The following is a description of a gene set: Human Gene Set: ZNF134_TARGET_GENES studied in species Homo sapiens from publication Yevshin I, Sharipov R, Kolmykov S, Kondrakhin Y, Kolpakov F (PMID 30445619) Genes containing one or more binding sites for (ZNF134) in their promoter regions (TSS -1000,+100 bp) as identified by GTRD version 20.06 ChIP-seq harmonization., and this is the list of marker genes: ELSPBP1, NRG4, HM13-AS1, THAP11, SCUBE2, SPOP, PADI2, LINC01409, RPS19, HLA-DMA, TNFSF13, HHAT, MCF2L, TTC24, PIGN, DOCK5, SCRN3, RBBP5, CUTA, MIR762HG, BLM, FSIP2LP, PRRG2, SQOR, TMPRSS2, FUNDC1, MT-RNR1, SCGN, GLDN, LINC01972, CCDC163, LINC01690, COL4A2, TMEM9, PHB1, C1RL-AS1, DNAJA2, LINC02041, MIR3621, KAZALD1, DLD, CCKBR, EFR3B, CLCN7, ATF6B, LINC01803, PXN, DUSP14, FHIP1B, IQSEC2, DROSHA, ZC3H12C, C10orf95-AS1, PSMA5, NUBPL-DT, MXD3, ERMN, DZIP3, STRA6, CRISPLD1, CD99L2, MAN1C1, STC2, POLR1B, OAS2, ARV1, LY6G5C, SF1 (splicing factor 1), ENSG00000233461, MAP4K1 (mitogen-activated protein kinase kinase kinase kinase 1), EPRS1, TUBG2, ZNF761, WEE2-AS1, LRRC10B, EEF1AKMT3, MIR1-1HG, CLDN6, MIR182, COPS7A, EVI5, C4orf50, LINC00649, AGAP3, DRC7, PNP, PSEN1, FOXN1, PPCDC, SELENOH, BCAT2, DPP8, COMMD3, ERCC1, RAI14, FOXP1, FOSB, PCGF6, RGL2 (ral guanine nucleotide dissociation stimulator like 2), SYNJ2BP-COX16, C5AR1, ALDH7A1, CDH13-AS2, UTP6, YBX3, LINC00111, NABP1, SLC25A15, MPG, GCSIR, PTPRF, YARS1, ELL, HOXC4, ATP6V1G1P5, WDR45, BORCS7, SNAP91, ISG20, DCTN1, ZNF565, NFE2, TOGARAM1, EGLN2, HACD2, TMEM101, RBMS3, CNN3, LRP10, VARS1, MIR933, KIF20B, R3HDM2-DT, FLAD1, PITPNM1, PRPF8, PDK4-AS1, ZNF616, DCUN1D3, CACNA1A, EML3, ZNF292, DST, TSNAX, GOT2, SOAT1, SLC11A2, SEC61G, FKBP15, SREBF1, B4GALNT4, IGDCC4, ZNF708, ITGA11, SLC22A11, TRAK2, CHMP6, NTN3 (netrin 3), FBXO27, SH3KBP1 (NCBI Gene Id 94010), ZNF460, PGGT1B, PDCD11, ZGRF1, EFL1P1, RNU4-60P, MRPL21, NSL1, CLVS2, CREM, EFEMP2, ZNF829, ALOXE3, SYNRG, BMPR1B, SYTL1 (synaptotagmin like 1), TEX10, ZSCAN31, CFLAR, SKAP2 (NCBI Gene Id 8935), OBSL1, GNAI3, SULT1A1, ZNF460-AS1, NIBAN1, NDUFA11, DCLRE1B, CCSAP, SEC24B, NLGN1, NCSTN, GCLM, BAIAP3, C5orf22, RNU6ATAC34P, ILF2, RPS6, ADAMTS13, SCAF4, PRR14, NFYA, FLII, RPL5, KRAS, WDR55, EXOC2, PIEZO2, ZNF160, LSMEM1, LINC02614, TENT5C, OARD1, TLCD3B, EME1, PRPH, LINC01063, LINC01132, LNCRNA-IUR, MIR4661, CIR1, HEATR1, ZEB1, EPHX1, RUSC1, DDOST, PPIEL, DYRK1A, TCHP, SFN (NCBI Gene Id 2810), LINC01152, SNUPN, GABPB2, ZNF429 (zinc finger protein 429), ENSG00000269151, RNF125, OSBPL7, MPND, ANKS3, BAZ2B, CEACAM1, UBE2V1 (NCBI Gene Id 7335), BMS1P4, TRIB1, OSBPL3, HMG20A, SYNJ2BP, SEH1L (NCBI Gene Id 81929), TLE6, JAKMIP2, SPCS2P2 (signal peptidase complex subunit 2 pseudogene 2), KIF3C, AKAP8, SEPTIN9-DT, DNA2, ZNF711, ANAPC2, PEAR1, RTEL1, SPECC1, SPTB, ATP2C1, MAP3K12, ENSG00000267698, ADHFE1 (NCBI Gene Id 137872), CHKB, SLC46A3, BFSP1, LINC02366 (long intergenic non-protein coding RNA 2366), GGA3, TCTN1, ACVR1C, CLPB, SREK1 (splicing regulatory glutamic acid and lysine rich protein 1), IL6, PIK3R2, CNEP1R1, MFAP3, PAMR1, ATXN1, IPO9-AS1, ANAPC5, ORC4, ATP5MC2, USP4, SF3A3, SZRD1, SDSL, DYRK1B, ESCO1 (establishment of sister chromatid cohesion N-acetyltransferase 1), PHETA1, COL9A3, WDR7, RASD2, CSNK1D, GPR157, NOLC1, TLL2, ZNF892, TBC1D14 (NCBI Gene Id 57533), TTF2, MIR4664, CD101-AS1, MTMR4, STAP2, NT5DC3, SLC12A6, RPS6KB1, ECHDC3, C9orf43, PDE9A, AGBL5-AS1, PNPLA8, ITGA7, CD72, PUS10, DNASE1, GTF2B, OTULINL, OTX1, PRKCG, CREB3L2, BBS1, SEC14L5, NPHS1, TMC4, ADAMTS1, TTLL6, ARRDC1, DENND4A, SARS2, GOLGB1, MAP2K5, ALDH4A1, ZNF133, THAP5, PDXK, SPNS2, ZNF233, ZNF569, LARP7, RBPJ, RBM26-AS1, LINC01937, STK11, ADGRB3, ZNF362, CGA, ZNF146, CYBA, MBLAC1, TMX4-AS1, KLHL28, TK2, NTAN1, PPP1R3B, ZFP30, GUSBP18, RIF1, PEX13, GPC1, ST7, RPL18, DAB2, ARHGAP27, WDR59, S100A1, TOP3A, SCAMP5, IRF3, DSG1-AS1, H2AZ1-DT, LIN28B, ARMC7, ZCCHC7, TMBIM1, PTCD3, SPSB4, SLC25A30, LINC02453, FBXL19-AS1, TPM3P9, GINS2, PTGES, LARGE2, MRM2, ABCA5, EBP, DPH3, PROSER1, ATG9B, DRAIC (downregulated RNA in cancer, inhibitor of cell invasion and migration), MIR4681, BLOC1S1, RNF115, SMPDL3A, H2AC4, TP53BP1, ACAD9, MAST4-AS1 (MAST4 antisense RNA 1), ATF2, ZNF420, OGT (O-linked N-acetylglucosamine (GlcNAc) transferase), S100A13, MIR4488, TBX18, KDM5A, BTN3A3, GOT1, B3GALNT2, WDR62, SPMIP8, CRHR1, IL23A, SMKR1, SEPTIN9, SMG1P3, SEPTIN11, RABGAP1L, RAD51C, DNAAF9, ZC3H15, APEX1, SYDE1, FOXK2, PUS1-AS1, B3GAT3 (NCBI Gene Id 26229), ZNF436, THAP10, PNRC2, LYRM1, SLC38A6, ZNF668, PNMT, AOPEP, GGNBP2, DPP9, KCTD16, PRRT1, MCCC1, MAST3-AS1, ZNF566, ZNF138, ARRDC3, SLC25A21, JADE2 (NCBI Gene Id 23338), H6PD, STING1, DLGAP5, LIMA1, SRP9, RNASEL, BORCS7-ASMT, CRTC3-AS1, NICN1, ZKSCAN8, VDAC1P8, PHF12, PDZD2, RASSF2, S100PBP, BMS1P4-AGAP5, C2CD3, MIR367, LINC00205, TRMT5, SELL, SBK2, GFAP, TM9SF4, ACTG1P12, HINT3, MICA, CBFA2T2, LARS1, LINC02970 (long intergenic non-protein coding RNA 2970), MIR302D, ANKRD13C, FTCD, STAT6, ITSN1, BRD4, USP44, FAM200A (family with sequence similarity 200 member A), DSN1, AARS1, PRPF18, PDE8A, RNF10, BBS4, LTBP4, TVP23C-CDRT4, TRIM2, KIAA0825, LINC00240, PGAM1P5, CDC14A, B4GALT3, PISD, NR4A1 (NCBI Gene Id 93352), NDUFA5, RNU11, CDK4, MACF1, STK40, BMP8B, RSBN1, PROSER3, SALL1, GAL3ST4, SIRT2, FMR1-AS1, TXNL1, MIR4519, GTPBP3, SGMS1, PACS1, HIP1R, SPTBN4, DNAH2, NR2F1, SEC61G-DT, STUM, SLC30A10, HNRNPR, ZBTB8A, WDR25, ENSG00000215156, GMEB1, TMEM186, CDC42SE1, ALDOA, ATP5MK, FAM114A2, TADA1, ZNF689, KIAA1217, GSAP, EBNA1BP2, PDP2, ZNF570, LNPEP, PEX11A, ABHD12, ZFYVE16, F11R, HOXB-AS3, NDEL1, SEC61A1, YAF2, FZD3, MT-TF, TNS2-AS1, DGKZ, PGAP1, PDE12, SEC22B, TNFAIP2, ZNF330, ARHGAP33, LINC01431, TMEM218, COL5A1, KIF22, SAMD14, DYNC2LI1, GLUD1P3, MCM7, MYLK-AS1, ODAD1, CSNK2B, PPHLN1, CAMSAP2, GABARAPL1, TBCB, PLAUR, TJP2, EEF2K, MAPK8IP3, PAN2, NEK2, NUP43, ANKRD13C-DT, CPNE7, HSPA8, EXOC4, RPL27 (NCBI Gene Id 6155), GLI2, CCDC57, SPHK2, NRP1, MYO3A, GTPBP8, EFHD2-AS1, SNHG22, RDM1, LTBP3, GOPC, TLN1, MIR7850, QRICH1, RPA3, CDR2, NT5M, CCNC, GIP, PDE4D, MSANTD4, BRINP2, PARN, SUGT1P4, C5orf34, IQANK1, LINC00910, TUBA1C, DPH1, TJAP1, NFKBIL1, SBNO1, JPX, MIR548AP, CXADR (NCBI Gene Id 95792), FHAD1, HNRNPD, RPL26, R3HDM2, ZFP36, STAT2, SNORA10, POLE3, ARHGEF37, ROM1, SMARCC2, TUBD1, HSD17B1-AS1, FAM133GP, C5orf47, PPME1, AGPAT5, GBA1, CRYZL1, HMCN1, GUSBP2, MIR22HG, SUPV3L1, ZNF285, EEF1A1, RNU4ATAC16P, MARCHF6, TSPAN12, DNAJB9, F12, BCAR3, TAPBP, VARS2, EGFL7, SGTB, PRPSAP2, PILRA, TM2D1, RUNX2, CCL3-AS1, NHLRC3, KCNAB2, PLXNB3, RNF166, NSUN6, AP1G1 (adaptor related protein complex 1 subunit gamma 1), ZNF655, MTMR9, ARID1A, RMC1, ZMYM5, NUP54, SSBP1, TACC2, PAXBP1, C2CD5, UBXN6, ITGAX, SLC16A13, C9, UACA, VWCE, ZNF85, MCTS2 (MCTS family member 2), FOXP1-DT, ZNF584, DLC1, HOXA9, ACTMAP, PMM2, MRPS31P5, LRRC49, TBCD, NFKBIB, LINC01523, LINC01039, CXXC5, RFFL, ATP6V1G2-DDX39B, ITGA9, PCYT1A, FBXO25, LRP8, HIF1A, PFDN1, SMC1A, ZNF92, VWA7, CPEB4, PCSK7, PAK4, RAB5B, RBMS3-AS3, PSTPIP2, COMMD9, ZNF391, THAP1, TLCD2, PHC2, ARHGAP24, NUB1 (negative regulator of ubiquitin like proteins 1), NID1, PEAK1, BCAP29, ANO8, NRCAM, LINC00957, MCM10, SLF1, FAM199X, MAML1, POLA2, MEGF10, GSK3B-DT, SRCAP, MCFD2, CNN3-DT, CDH23, TATDN3, ENSG00000272008, MAML3, MT1X, MAP3K15, ACIN1, GSR, OSBPL8, TREX1, HNRNPD-DT, TENT5C-DT, RNF19A, UVRAG, LCN15, COX16, PPT2, CDKN1A, KLHL20, RNU7-179P, SF1-DT, LSP1, SNORD21, LYZL6, SRD5A3, MMACHC, RNF145, CRYL1, ATP5MC3, RNF13, FAM8A1, GOT1-DT, SUZ12P1, GTPBP6, ZFHX2, SQSTM1, MFN2, LINC01778, COPA, SPAG1, ARL6IP6, CDK15, PMEL, HOXB-AS1, REPS1, CHEK2, SNORA14B, CTBP2, SDCBPP3, ORAI2, ZFP64, PARP1, KDM4A, ZNF385A, YIPF5, PIK3AP1, PPP6R3, IL12RB1, LINC02458, PYCR1-AS1, FAM186A, ARPC5 (NCBI Gene Id 10092), FBXL19, IKBKB-DT, PYGM, TMCC3 (NCBI Gene Id 57458), NUP153, DOHH, ZNF500, E4F1, RPP21, GFI1, MYL6B, IPO4, METTL1, TBPL1, TAB2, TARBP2, MAST4, KRT8, IER5L-AS1, VPS33B, MDGA1, PATL1, RASA4CP, RIC8A, AGBL5, NUBPL, ARHGAP5, ATP5PD, CHD1, PDE6B, SPRY1, NEMF, CNOT2, GGT1 (NCBI Gene Id 91347), RNF103-CHMP3, MRPL27, OXNAD1, PMVK, PRSS22, SLC9A3R1-AS1, WDR26, TVP23C, DSTN, PDE7A, PKN2, TASOR2, ZNF737, BCAN-AS2, MIR6853, PSMB5, HOGA1 (NCBI Gene Id 112817), ARHGEF7, ALKBH6, TEX14, ZNF714, GNG12-AS1, BEST3, RERE, ENDOG, GTF2H4, LETM2, TMEM184A, NAPEPLD, WDFY1, ROGDI, C1RL, POLR3C, COQ5, CEP89, GLI1, CHKB-CPT1B, TNS2, SLC25A14, NEK2-DT, GLIPR1L1, JUP, GPD1, ATN1, SNORD118, DMAP1, KSR1, RNY1, ZNF287, PHC3, ZDHHC2, CYP2J2, MYO3B-AS1, AMFR, RN7SKP276, CPEB1, CIP2A, SESN3, MGST1, CAMKK1, SALL1P1, RREB1, CSF3R, CHKB-DT, AGPAT1, MTND5P11, LINC01863, TDRD7, FGF1 (NCBI Gene Id 29961), DNAI3, NOSIP, RUSC1-AS1, EPCIP-AS1, AGPAT4, IPO9, PDGFRL, HOMER3, XIAP, SV2C, NPTX1, CARS2, WDR93, PHYHIP, ATP1B3, IDE, CSNK1A1, ENOSF1, DST-AS1, ENSG00000214708, U2AF2, LYPD5, MTCO3P12, ZNF568, ATP6V1G2, CCDC6, C6orf118 (NCBI Gene Id 353266), DUSP18, OSGEP, PPP1R12A-AS2 (NCBI Gene Id 105369864), FKBP14-AS1, CLIC1, H2AC25, HRCT1, CFAP57, ACAN, LGMN (NCBI Gene Id 5641), PRDM4, CCNG1, MPZL1, VPS33B-DT, ERI2, ZNF428, QNG1, ZNF566-AS1, TIAL1, FMR1, RIBC1, LIN37, FHL1P1, WSCD1, HSPB6, ZFP1, HECW2, YAP1, CFDP1, LNCTSI, CEBPB-AS1, BCL2L12, SNRPA, ZNF131, KCNT1, NUFIP2, ST6GALNAC6, EVL, IMP3, MCTS1, NCEH1, METTL9, NPHP4, TTC13, NINJ2, GDI2, HOXB2, DCDC2, LYPLA2, ETV2, RGS9, ZNF672, KDM4B, NMT1, RELCH, AGBL3, TGFBI, CNTNAP2, ASB6, IGHV3-30-2, ZNF229, CCDC88C, CFAP65, MBD5 (methyl-CpG binding domain protein 5), TMEM170A, MCPH1-AS1, RNA5SP433, PDCD2L, ITPR1, POLR3G (RNA polymerase III subunit G), STPG3-AS1, ARHGAP5-AS1, LINC02250, BRD2, TSC22D4, HIGD2B, RNF103, FICD, CIBAR1, BNC2-AS1, RAB11A, VMAC, TVP23B, EFHD2, MARCHF6-DT, PTGES3, DHRS4-AS1, ACHE, UBE2I, IGFBP3, LINC02136, GPANK1, FAM83H, LRP8-DT, PCBP3, SLC1A3-AS1, DHDDS, RAET1K, WFDC2, ACTB, SPEN, SPINT2, NOL4L, SLC2A8, LRRC24, RCOR1, ABR, AKR1A1, ABCG4, GRHL3, EXOSC8, MRPS21, RGL1, HM13, RFC1, PRSS16, CFAP74, KANK3, FAAP24, ENSA, PHLPP2, ALG5, FGGY, CSTB, MC1R, DCTD, MIR760, EPN3, UBE2O, FLOT1, ZNF543, CALM1, POP4, LINC01607, ENSG00000282849, ERCC3, IFT140, CSK, LINC01569, SFR1, ZMYM4, ACP6 (acid phosphatase 6, lysophosphatidic), CDR2-DT, ENSG00000261070, BCRP2, KCTD2, MBTPS2, RNU6-1010P, ANXA2R, SUB1, EP400P1 (EP400 pseudogene 1), CATSPERG, LHFPL4, ZNF541, CIBAR1-DT, NBPF1 (NBPF member 1), PRELID3A, AKR1D1, PNCK, WEE1, MIR4521, CEP131, REEP2, CCDC167, APLP1, MYOCD-AS1, POLR2F, MAP4K1-AS1, NTMT2, CCDC77, GRIPAP1, KCNK1, CUL4B, HNRNPC, TSNAX-DISC1